Given this list of marker genes Mb, Hbb-bh1, Hbb-bh0, Hbb-bs, Hba-a1, Hba-x, Ngb, Bpgm, Cygb, Hbb-y, here is a description of the gene set: The directed movement of oxygen (O2) into, out of or within a cell, or between cells, by means of some agent such as a transporter or pore. Mouse Gene Set: GOBP_OXYGEN_TRANSPORT species: Mus musculus